Given this list of marker genes BIK, PIM1, TNFRSF1B, CEBPE, RARG, SLC2A5, ELF4, CEBPA, IRF1, FGR, JUND (NCBI Gene Id 3727), IER3, CD38, NDRG1, IGFBP6, PSAP, IDH1, TOP1, LITAF, UPP1, NCF1, SEMA4D, LSP1, TNFAIP2, HOXA1, SLA, SPI1, PKN1, ARHGAP45, ALOX5AP, here is a description of the gene set: Genes up-regulated by tretinoin (ATRA) in U937 cells (acute promyelocytic leukemia, APL) made sensitive to the drug by expression of the PML-RARA fusion. Acute promyelocytic leukemia (APL) is associated with chromosomal translocations involving retinoic acid receptor alpha (RAR alpha) and its fusion partners including promyelocytic leukemia (PML) and promyelocytic leukemia zinc finger (PLZF). Using oligonucleotide arrays, we examined changes in global gene expression mediated by the ectopic expression of either PML/RAR alpha (retinoid-sensitive) or PLZF/RAR alpha (retinoid-resistant) in U937 cells. Of more than genes analyzed, genes were commonly up-regulated, and genes were down-regulated by both fusion proteins suggesting their role in the APL phenotype. In our APL model, for example, TNFAIP2, TNFR2, ELF4, RAR gamma, and HoxA1 were down-regulated by both fusion proteins in the absence of retinoic acid (RA). RA strongly up-regulated these genes in PML/RAR alpha, but not in PLZF/RAR alpha expressing U937 cells. Expression studies in NB4, retinoid-resistant NB4-R2, normal human CD34+ cells, and APL patient samples strongly suggest their role in the regulation of granulocytic differentiation. Furthermore, combined treatment with tumor necrosis factor alpha (TNF alpha) and RA synergistically enhanced granulocytic differentiation in NB4 cells but not in NB4-R2 cells. Our data indicate that APL pathogenesis and retinoid-induced granulocytic differentiation of APL cells involve genes in the cell death pathway, and that cooperation between the RA and TNFalpha signaling pathways exists. Targeting both the retinoid-dependent differentiation and the cell death pathways may improve leukemic therapy, especially in retinoid-resistant acute myeloid leukemia. Human Gene Set: PARK_TRETINOIN_RESPONSE_AND_PML_RARA_FUSION studied in species Homo sapiens from publication Park DJ, Vuong PT, de Vos S, Douer D, Koeffler HP (PMID 12893766)